Given this list of marker genes HCLS1, LEF1, HAX1, IL5, TRIB1, TESC, RUNX1, EVI2B, MIR486-1, here is a description of the gene set: studied in species Homo sapiens Any process that activates or increases the frequency, rate or extent of granulocyte differentiation. Human Gene Set: GOBP_POSITIVE_REGULATION_OF_GRANULOCYTE_DIFFERENTIATION